The following is a description of a gene set: studied in species Mus musculus The function of a family of small chemotactic cytokines; their name is derived from their ability to induce directed chemotaxis in nearby responsive cells. All chemokines possess a number of conserved cysteine residues involved in intramolecular disulfide bond formation. Some chemokines are considered pro-inflammatory and can be induced during an immune response to recruit cells of the immune system to a site of infection, while others are considered homeostatic and are involved in controlling the migration of cells during normal processes of tissue maintenance or development. Chemokines are found in all vertebrates, some viruses and some bacteria. Mouse Gene Set: GOMF_CHEMOKINE_ACTIVITY, and this is the list of marker genes: Ccl19-ps3, Cxcl11, Cxcl16, Ccl21e, Ccl8, Ccl21b, Cxcl15, Ccl24, Ccl19, Ccl19-ps5, Ccl12, Cxcl10, Cxcl12, Cxcl3, Ppbp, Ccl28 (NCBI Gene Id 56838), Ccl1, Ccl3, Cxcl2, Ccl19-ps1, Ccl5, Ccl27a, Ccl25, Xcl1, Gpr15lg, Ccl11, Cklf, Ccl21f (C-C motif chemokine ligand 21F), Cxcl1, Ccl20, Ccl22, Ccl26, Cxcl5, Ccl2, Cx3cl1, Cxcl14, Pf4 (NCBI Gene Id 56744), Ccl21a, Cxcl17, Ccl17, Cxcl13, Ccl6, Cxcl9, Ccl9, Ccl4, Ccl19-ps6 (NCBI Gene Id 100861647), Ccl21d, Ccl19-ps4, Ccl7